Given this list of marker genes CLVS2, SPATA4, FRMD4B, PPM1E, ZBTB38, PSMC6, FAM184A, ECM2, GPATCH2L, C5orf24, GPR22, FERMT2, MBNL1, NPAS2 (neuronal PAS domain protein 2), NPTX2, EPC2, FAM168A, GIGYF2, YME1L1, ZC4H2, ERRFI1, METTL21A, C1QC, SPAST, SPECC1, HNRNPR, PDLIM5, GABARAPL2, CCN1, HDGFL3, TMEM263, KCNJ1 (potassium inwardly rectifying channel subfamily J member 1), SMC6, RBM24, PAK3, KIF5B, SORCS1, RAP1B, RNF13, NEO1, PTPRQ, PDC, SCOC, FBXO11, OLFML2B, SMARCD1, NUP160, ULK2, YTHDF2, SMIM13, CLEC17A, TBC1D30, DOP1B, TCEAL4, TENM1, CBLL1, SOCS5, RNF103, ORC5, CBX5, WDR33, AGFG1, TRIM48, here is a description of the gene set: Human Gene Set: MIR323B_3P Genes predicted to be targets of miRBase v22 microRNA hsa-miR-323b-3p in miRDB v6.0 with MirTarget v4 prediction scores > 80 (high confidence targets). species: Homo sapiens from publication Chen Y, Wang X (PMID 31504780)